The following is a description of a gene set: Human Gene Set: GARGALOVIC_RESPONSE_TO_OXIDIZED_PHOSPHOLIPIDS_SALMON_DN Genes from the salmon module which are dn-regulated in HAEC cells (primary aortic endothelium) after exposure to the oxidized 1-palmitoyl-2-arachidonyl-sn-3-glycerophosphorylcholine (oxPAPC). from publication Gargalovic PS, Imura M, Zhang B, Gharavi NM, Clark MJ, Pagnon J, Yang WP, He A, Truong A, Patel S, Nelson SF, Horvath S, Berliner JA, Kirchgessner TG, Lusis AJ (PMID 16912112) Oxidized phospholipids are thought to promote atherogenesis by stimulating endothelial cells (ECs) to produce inflammatory cytokines, such as IL-8. In studies with mouse models, we previously demonstrated that genetic variation in inflammatory responses of endothelial cells to oxidized lipids contributes importantly to atherosclerosis susceptibility. We now show that similar variations occur in cultured aortic ECs derived from multiple heart transplant donors. These variations were stably maintained between passages and, thus, reflect either genetic or epigenetic regulatory differences. Expression array analysis of aortic EC cultures derived from 12 individuals revealed that >genes were regulated by oxidized phospholipids. We have used the observed variations in the sampled population to construct a gene coexpression network comprised of 15 modules of highly connected genes. We show that several identified modules are significantly enriched in genes for known pathways and confirm a module enriched for unfolded protein response (UPR) genes using siRNA and the UPR inducer tunicamycin. On the basis of the constructed network, we predicted that a gene of unknown function (MGC4504) present in the UPR module is a target for UPR transcriptional activator ATF4. Our data also indicate that IL-8 is present in the UPR module and is regulated, in part, by the UPR. We validate these by using siRNA. In conclusion, we show that interindividual variability can be used to group genes into pathways and predict gene-gene regulatory relationships, thus identifying targets potentially involved in susceptibility to common diseases such as atherosclerosis. studied in species Homo sapiens, and this is the list of marker genes: LYN, PIK3R3, PROX1, VGLL4, PIK3IP1, APOL3, CXADR, NUDT4, TRIM25, ARHGEF37, GMPR, KLRG1, GJA4, CYRIA, ADGRG6